Given this list of marker genes Lpcat2b, Gpam, Gpat2, Cpt1a, Agpat2, Pla2g4c, Lcat, Lpcat1 (NCBI Gene Id 97903), Agpat1, Gnpat (NCBI Gene Id 51942), Agpat3, Soat1, Lpcat3, Mboat7 (membrane bound O-acyltransferase domain containing 7), Mogat2, Crat, Prdx6b, Soat2, Pla2g4a, Cpt1b, Prdx6, Gpat4, Plaat1 (phospholipase A and acyltransferase 1), Apoa5, Lpgat1, Gpat3, Nat2, Awat1, Apoa1, Lpcat2, Awat2, Casd1 (NCBI Gene Id 213819), Mogat1, Pnpla3, Apoe (apolipoprotein E), Pla2g15 (phospholipase A2, group XV), Dgat2, Pigw, Ifnb1, Mboat2, Lpcat4, Cpt2, Crot, Chat, Mboat4, Lclat1, Dgat1, Agpat5, Mboat1, Lrat, Nat3, Apoa4, Pnpla2, Nat1, Porcn, Agpat4, Tafazzin, Dgat2l6, Apoa2, Cpt1c, Acat1, Abhd5, here is a description of the gene set: Mouse Gene Set: GOMF_O_ACYLTRANSFERASE_ACTIVITY species: Mus musculus Catalysis of the transfer of an acyl group to an oxygen atom on the acceptor molecule.